Given this list of marker genes NELFE, PACSIN2, FARP1, NACA, PGM2, TXNRD3, CMTM5, TYRO3, OSBPL6, GET1, DCBLD2, CCN1, SOX5, SF3A2, RLBP1, EBPL, AURKB, TAMALIN, FOXK2, CDC42EP5, CKAP2L, RNF26, TMED2, ANO3, DNM1, FAM3B, PMF1, MKI67, CLYBL (citramalyl-CoA lyase), ERGIC1, KPNB1, SPIRE1, CDK1, GTF2E2, FJX1, MVK, NDUFC2, KREMEN1, GPD1, PCBP4, PRR11, TUBG2, ABCA12, TOM1L2, HMGB3, CALU, SLC25A10, CYP20A1, RPL31, PKP2, TPX2, TSPAN12, TOMM6, LMF1, CDR2, CDK2AP1, TLCD3A, RNF144A, LDLRAD3, MLPH, SKA2P1, SC5D, PPIL1, CHAF1B, PPARGC1A, DUSP4, TIMP4, PIP5K1B, FKBP2, AK4, EEFSEC, MSMO1, AIMP2, CCNE1, CDHR2, CDCA7, KIF18B, ALYREF, GYS1, NEK10, FAM174B, LMNB1, CENPA, MYBL2, PFDN1, HK1, ST3GAL1, CNTFR, MCM10, SHCBP1, SMTNL2, SLC6A17, PRELID2, PRSS12, TECR, REEP3, SLC31A1, VCL, R3HCC1, SLC27A4, PHB2, CKAP5, TIMM50, FRMD3, LSM14B, PERP, DBF4, KIF2C, ARHGAP19, STAC2, LRRN4CL, MAPK8IP1, FRZB, RENBP, NUDT16L1, BRI3BP, DHCR7, SYDE1, NDRG2, USP6NL, TXNDC5, LDLR, STARD4, GPT, RPL38, CDCA3, SCD, FADS1, CRIP2, FAM83D, COX8BP, RSL1D1, TMEM201, CSNK1E, H2AZ1 (NCBI Gene Id 3015), ARSG, NET1, APOLD1, RPS6KA2, DHCR24, SLC2A5, DLGAP5, TBL2 (transducin beta like 2), PRKAG1, MYL6B, BEND6, ALDH1L2, CRLF1, DHPS, PGF, TET1, IDH2, E2F1, ZDHHC2, MBOAT1, RPL37 (NCBI Gene Id 6167), SHC3, NCAPH, MRAP, INSIG1, TACC1, XXYLT1, PGP, ROGDI, STAU2, NDUFB10, TMPO, NACC1, FUCA1, ELOVL6, NEK2, HDLBP, NCKAP5L, ACVRL1, PHF2, ANLN, BCAS1, NR1I2, RACGAP1, CTXN1, MYL9 (NCBI Gene Id 10398), here is a description of the gene set: Genes up-regulated in immature dendritic cells: untreated versus interferon alpha. Human Gene Set: GSE7509_UNSTIM_VS_IFNA_STIM_IMMATURE_DC_UP from publication Dhodapkar KM, Banerjee D, Connolly J, Kukreja A, Matayeva E, Veri MC, Ravetch JV, Steinman RM, Dhodapkar MV (PMID 17502666) The ability of dendritic cells (DCs) to activate immunity is linked to their maturation status. In prior studies we have shown that selective antibody-mediated blockade of inhibitory FcgRIIB receptor on human DCs in the presence of activating immunoglobulin (Ig) ligands leads to DC maturation and enhanced immunity to antibody-coated tumor cells. Here we show that Fcg receptor (FcgR) mediated activation of human monocytes and monocyte-derived DCs is associated with a distinct gene expression pattern, including several inflammation associated chemokines as well as type 1 interferon (IFN) response genes including the activation of signal transducer and activator of transcription 1 (STAT1). species: Homo sapiens